Given this list of marker genes YME1L1, NAP1L2, SMYD5, LBH, CDK2AP2, MIR145, PRDM15, NCOA3, SOX17, SFRP2, ESRRB, EVI2B, MLLT3, here is a description of the gene set: species: Homo sapiens Any process that modulates the frequency, rate or extent of stem cell division. Human Gene Set: GOBP_REGULATION_OF_STEM_CELL_DIVISION